Given this list of marker genes Ptk2, Apbb1ip, Grb2, Itga2b, Fgg, Shc1, Csk, Bcar1, Syk, Rasgrp1, Pdpk1, Ptpn1 (NCBI Gene Id 19246), Crk, Tln1, here is a description of the gene set: part of: Platelet Aggregation (Plug Formation); Signal Transduction electronically inferred by orthology from the curated human pathway This event has been computationally inferred from an event that has been demonstrated in another species.<p>The inference is based on the homology mapping from PANTHER. Briefly, reactions for which all involved PhysicalEntities (in input, output and catalyst) have a mapped orthologue/paralogue (for complexes at least 75% of components must have a mapping) are inferred to the other species. species: Mus musculus Reactome Pathway: Integrin signaling